Given this list of marker genes Il17rd, Itgb3, Tln1, Map2k2, Ksr1, Braf (NCBI Gene Id 97330), Csk, Iqgap1, Rap1a, Arrb2, Kras, Cnksr1, Actg1, Vwf, Src, Raf1, Mapk1, Cnksr2, Arrb1, Actb, Rap1b, Map2k1, Ksr2, Ywhab, Araf, Mapk3, Fga, Vcl, Apbb1ip, Lamtor2, Hras, Fgb, Lamtor3, Wdr83, Mark3, Itga2b, Pebp1, Fn1, Fgg, here is a description of the gene set: Mouse Gene Set: REACTOME_MAP2K_AND_MAPK_ACTIVATION MAP2K and MAPK activation studied in species Mus musculus